The following is a description of a gene set: Validated transcriptional targets of deltaNp63 isoforms species: Homo sapiens from publication Schaefer CF, Anthony K, Krupa S, Buchoff J, Day M, Hannay T, Buetow KH (PMID 18832364) Human Gene Set: PID_DELTA_NP63_PATHWAY, and this is the list of marker genes: MDM2 (NCBI Gene Id 84825), CCNB2, POU2F2, KRT14, PPP2R5A, VDR, GPX2, TBXT, COL5A1, TOP2A, NRG1, DLX5, TCF7L1, AXL, IGFBP3, STXBP4, PERP, WWP1 (NCBI Gene Id 81891), GSK3B (NCBI Gene Id 2932), ATM, CDKN2A, BRCA2, FASN (NCBI Gene Id 2194), HELLS, SFN, NOTCH1, RUNX1, RACK1, TP63, ADRM1, HBP1, CEBPD, KRT5, ITGA3, YAP1, FBXW7, SEC14L2, MRE11, ADA (NCBI Gene Id 100), FOSL2, ITCH, IL1A, RAB38, DLX6, BDKRB2, RRAD, HES1 (NCBI Gene Id 3280)